The following is a description of a gene set: The switching of activated B cells from IgM biosynthesis to biosynthesis of an IgA isotype, accomplished through a recombination process involving an intrachromosomal deletion between switch regions that reside 5' of the IgM and one of the IgA constant region gene segments in the immunoglobulin heavy chain locus. Human Gene Set: GOBP_ISOTYPE_SWITCHING_TO_IGA_ISOTYPES species: Homo sapiens, and this is the list of marker genes: CCR6 (NCBI Gene Id 1235), MLH1, TNFSF13, MSH2, NSD2, PMS2, TGFB1